The following is a description of a gene set: Catalysis of the reaction: lysophosphatidic acid + H2O = phosphate + monoacylglycerol. studied in species Homo sapiens Human Gene Set: GOMF_LYSOPHOSPHATIDIC_ACID_PHOSPHATASE_ACTIVITY, and this is the list of marker genes: PLPP6, PLPPR1, EPHX2 (epoxide hydrolase 2), PLPP1, ACP3, ACP6, PLPPR4